The following is a description of a gene set: Mouse Gene Set: GOBP_PARACRINE_SIGNALING species: Mus musculus The transfer of information from one cell to another, where the signal travels from the signal-producing cell to the receiving cell by passive diffusion or bulk flow in intercellular fluid. The signaling cell and the receiving cell are usually in the vicinity of each other., and this is the list of marker genes: Cgas, Tnfsf11, Cd34, Pgr, Pdgfb, Fgf2, Dhh (desert hedgehog)